The following is a description of a gene set: Germinal centers (GCs) are clusters of activated B cells built on stromal cells known as follicular dendritic cells (FDCs). In the Peyer’s patches (PPs), GCs are chronically induced by bacteria and are the major sites for generation of gut IgA immune responses. Whether FDCs directly contribute to the IgA production in PP GCs is unknown. To investigate the role FDCs in gut immune system, we examined comprehensive gene profiles of FDCs purified from PPs or perypheral lymph nodes (pLNs) with or without immunization. We also tried to reconstitute the PP FDC signature in vitro by pulsed or continuous stimulation of pLN FDCs through TLRs, RARs or simultaneously through TLRs and RARs. studied in species Homo sapiens Genes down-regulated in the in vitro follicular dendritic cells from peripheral lymph nodes (96h): tretinoin versus tretinoin and Pam2CSK4. Human Gene Set: GSE19401_RETINOIC_ACID_VS_RETINOIC_ACID_AND_PAM2CSK4_STIM_FOLLICULAR_DC_DN from publication Suzuki K, Maruya M, Kawamoto S, Sitnik K, Kitamura H, Agace WW, Fagarasan S (PMID 20643338), and this is the list of marker genes: CHKA, IKZF1, CHST11, CTNNBIP1, CCNF, ELAVL4, ZNF132, NDUFC2, RETREG2, MICAL3, ZNHIT1, ENSG00000274253, OSER1, DIP2C, USP21, NOL9, MSH6, ANAPC1, TRIAP1, RPL24, PAXIP1, DRG2, BTK, CRYAA, RNF208, UBE4B, DOK1, EHMT2, PACSIN2 (NCBI Gene Id 150377), EIF4H, TBC1D2, TMEM187, PTPRJ, BCL11A, SLC2A4RG, SEC14L5, CBX5 (NCBI Gene Id 23468), GLOD4, PCMT1, POFUT1, MRPL34, GRB2, HOXC6, TCTA, TINF2, TFB1M, MDK, SART1, BAG5, NMU, PSMC4, MZT2A, STMN1, MYCN, CPNE1, MCUB, GLRB, TOP3B, RHBDD3, KIF17, RANGRF, PRAME, SNRPD2, PIK3CD, ZDHHC3, SLC10A3, PYGO1, LMNB2, KRT18, GRIN1, LRFN4, LIN37, TKFC, EML3, SEPTIN8, TMEM63A, CEACAM3 (CEA cell adhesion molecule 3), RAD17, ACTR1A, CHST12, ACTR2, LSM4, SLC37A4, JADE2 (NCBI Gene Id 23338), SAP18, KCNC4, DDT, SPECC1L, NANOG, ZDHHC18, SETD4, PSMC3, KIF3C, RNFT2, SMARCD3, HIRIP3, SETD2, ETV5, AAMDC, ZNF646, MAGI1, SCCPDH, ARHGEF3, HADHA, PPFIA3, FAM117A, GPNMB, RPL18, MRPL16 (mitochondrial ribosomal protein L16), PPP6R3, GAPVD1, RPRD2, EXTL3, DNAAF5, OR3A1, KIAA0930, PRDM11, SELPLG, GNAZ, RALBP1, SCRN3, TRMT9B, MLLT3, DTX3, COTL1, TACC3, FKBP10, GLT8D1, POLR3B, AGFG2, E2F1, LCE2B, TMEM19, STEAP3, HOXB9, FOXM1, YY1AP1, VDAC1, PTCD1, LSS, LGALS9, ZNF268, NR5A2, LMO1, ANKRD27, TRAM2, TMEM242, ALDH5A1, AEN, TRAPPC3, PAFAH2, PCBP2, HOMER2, RAPGEF2, RTN3, TMED3, DBNDD1, CAD, GCNT4, RPS7, PINLYP, SEC22A, BIN2, KDM3B, PC, SAC3D1, AP4M1, METTL3, TEC, CENPA, PGC, GRP, TTBK2, PSMB1, MYO1F, SYNRG, FKBP6, PIP4K2B, ASH2L, VASH2, ACAA2, ACAT2, WDR70, ELMO2, GRAMD1B, B3GALT4, GFI1, H3C2, IRF3, DDX19A, BICD2, RAB32, MIOS, VILL, TCOF1, SPG21, OSTF1, PDCD6, INPP5D